Given this list of marker genes FILIP1, B3GAT3, VIPAS39, TH, PEX5, COL5A1, BIN1, B4GALT7, HSPB1, SMARCAL1, ESCO2, FLI1, EDEM3, ZNF699, DES, TAFAZZIN, SYT1, IFT27, CHMP1A, WNK3 (WNK lysine deficient protein kinase 3), BBS4, CCNQ, RINT1, MYL2, SALL1, CEP55, FGD1, HYLS1, PTRH2, PLA2G6, TRPM3, NEDD4L, PYCR1, FHL1, COMT, LIFR, NEB, SDCCAG8, DGCR8, SKI, SLC6A9, FGD4, FBLN5, PDHA1, GJA5, SYNE1, BBS2, KIDINS220, SOX9, SNCA, H1-4, TTC8, TAF6, AMER1, SPECC1L, MAN2B1, COG8, DLAT, VPS33B, SMAD3, DYM, BBS9, TRIM2, MYMX, IMPDH2, NEK9, SLC26A2, DONSON, KAT6B, COLQ (NCBI Gene Id 8292), NALCN, NIPBL, GAD1, MYMK, TCTN2, GRIA2, TOR1A, CCN2, TBX15, CHRNG (cholinergic receptor nicotinic gamma subunit), ELN, HSD17B4, TXNDC15, NR4A2, REV3L, BBIP1, MAP3K20, DHX16, ERCC2, FKTN, TMEM237, DYNC2H1, BMPER, RUSC2, MYH8, FBXO7, KYNU, NDRG1, BBS7, KIF1A, RAI1, GTPBP2, BLTP1, NKX3-2, SNIP1, L1CAM, ATP6V0A2 (NCBI Gene Id 7854), MTRFR, ERGIC1, ATP6V1E1 (NCBI Gene Id 529), AHDC1, LETM1, SEC24C, CCBE1 (NCBI Gene Id 147372), RAD21, IL6ST, RAP1GDS1, EIF2S3, GZF1, GDAP1, PLK4, ITGA7, CLCN3 (chloride voltage-gated channel 3), LMX1B, COL1A2, MYPN, BBS1, PAICS, MPZ, SCLT1, HRAS, IFIH1, FKBP14, TMCO1, COL3A1, ORC6, SLC31A1, TWIST2, ARSI, GSC, OTUD5, VANGL1, HACE1, KANSL1, NKAP, ALDH18A1, SETBP1, ATAD1, DCHS1, DHCR7, TP63, DGCR6, MEGF10, EEF1A2, TRIP11, POLR3A, ZC4H2, OTUD6B, ALDH1A2, PPP3CA, SUZ12, IPO8, LZTFL1, SCYL1, ERBB2, COL12A1, C12orf57, GLB1, ESAM, EBP, JMJD1C, DOK7, YME1L1 (NCBI Gene Id 115724), SATB2, LONP1, LBR, ECEL1, GLE1, VAPB, TFE3, GPX4, CNTNAP1, CTDP1, SALL4, B9D2, UFD1, MYT1L, POLR3GL, BICD2, COG4, TBC1D23, CHST3, PEX1, LMNA, SH3PXD2B, TSPOAP1, PIGL, ADAMTS15, TBX1 (NCBI Gene Id 7413), WARS2, WBP4, ARHGAP31, MCTP2, UNC80, PLOD3, FAT4, SEMA3E, COG1, EHMT1, CCDC47, PEX26, SEC31A, COQ8A, ENTPD1, SNX14, SMC1A, FGFRL1, RECQL4, AP4E1, ITGA8, WDPCP, ATAD3A, IFT172, AMMECR1 (AMMECR nuclear protein 1), MED13L, SELENON, MTTP, STAC3, B9D1 (NCBI Gene Id 27077), PRUNE1, DPYS, STXBP1, BBS12, DSE, TCTN1, VWA1, MAN2C1, RYR3, RBPJ, SCN4A, TMTC3, SLC35D1, GP1BB, BRD4, ZNF148, EXT1, CHRM3, GLI3, MKS1, ACTA1, DST, CTBP1, IRF6, ERCC5, PIEZO2, NADSYN1, KY, CTCF, ADGRG6 (NCBI Gene Id 57211), TMEM216, LMBRD1, CRLF1, DHCR24, MYBPC1, RIPK4, CACNA1C, SHROOM4, ADAT3, SH3TC2, IFT74, SPEG, PSAT1, GPC4, MAP3K7, DOCK6, NT5C2, FLVCR2, POR, ALG14, NPHP1, SLC35A2, ARVCF, CC2D2A, MTMR2, CPLX1, ZIC3, FUZ, B3GALT6, LMBR1, MET, SLC25A19, DMPK, FOXG1, AP4M1, FIBP, AP4S1, POLRMT, TPM2, IGHMBP2, TBX4, PITX1, PEX2, TGDS, SMOC1, GBE1, GJA8, TGFBR2, HSPG2, CILK1, CREBBP, WNT7A, BRPF1 (NCBI Gene Id 7862), CFAP418, ERMARD, ATRX, SCAPER, CSPP1, PMP22, SAMD9, HDAC8, COL2A1, COL6A1, ALG3, ORC1, NELFA, HBA1, GUSB, ALG8, ZSWIM6, ROBO1, MYH7, LAMB2, TNNI2, CRIPT, HIRA, ARL6, BAP1, GCH1, DGCR2, SBF2, SMARCA2, TGFB2, CLTCL1, ATP6V1A, NEK8, SPTBN1, LIMS2, CACNA1B, GPC3, CHD7, HACD1, ACBD6, MFN2, LAMA5, FLNB (NCBI Gene Id 8413), HK1, EIF4A3, NOTCH1, PUF60, EOGT, SMS, FBN1, GNPTAB, TAF8, FA2H, TNNT3, ABHD16A, TPM3, KDM5C, TMEM67, VRK1, SMC3, BMPR1B, RBM8A, CEP290, MSX1, PLOD2, COASY, HAAO, HBA2, TRPS1, MKKS, MYL11, COL1A1 (collagen type I alpha 1 chain), TRIM32, FANCL, HNRNPK, MAPK1, PI4KA, CTU2, ERCC6, ESS2, CEP19, SCARF2 (NCBI Gene Id 91179), TMEM231, TTN, WDR73, DYNC1H1, BBS10, NFU1, DLL4, MYH3, RAB11B, TRAIP, KMT5B, TGFBR1, ALG12, ERCC1, SF3B4, ALG9 (ALG9 alpha-1,2-mannosyltransferase, NCBI Gene Id 79796), PLEKHG5, LGI4, IHH, BBS5, NEFL, SC5D (sterol-C5-desaturase), NSD2, STX5, FLNA, CHST14, CTNNA2, GDF5, MFSD2A, MUSK, RSPO2, UBE2A, RPGRIP1, ANK1, TTI1, MEGF8, EZH2, CHN1, DRG1, TMEM107, GLDN (gliomedin), FBN2, CTH, RBM10, CD96, GORAB, EVC2, SNRPN, RAB3GAP2, NSD1, MYO9A, TRPV4, NECTIN1, RREB1 (ras responsive element binding protein 1), MAFB, TGFB3, CANT1, COL5A2, FKBP10, BCOR, EVC, EP300, TAF1, APC2, TCTN3, NDE1, PLOD1, ATR, PTEN, GAN, RAB23, PLXND1 (NCBI Gene Id 23652), PIGG, USP8, AP4B1, PIGB, REEP1, RYR1, TWIST1, RPGRIP1L, JPH1, FXN, here is a description of the gene set: A foot deformity resulting due to an abnormality affecting the muscle and soft tissue. In contrast if the bones of the foot are affected the term structural foot deformity applies. Positional foot deformity Human Gene Set: HP_POSITIONAL_FOOT_DEFORMITY species: Homo sapiens